Given this list of marker genes CDK5 (NCBI Gene Id 1020), NDUFA4, NDUFB7, MT-ND1, NDUFA3, NDUFB5, NDUFV1, NDUFB2, NDUFA7 (NADH:ubiquinone oxidoreductase subunit A7), NDUFB3, NDUFAB1 (NCBI Gene Id 4706), NDUFA6, NDUFS1, MT-ND4, NDUFS5, NDUFB11, NDUFS8, MT-ND2, CDK5R1, MT-ND6, CAPN1, NDUFS4, NDUFB9, NDUFS3, NDUFS2, NDUFC1 (NCBI Gene Id 4717), NDUFC2, MAPT, NDUFA11, NDUFB8, NDUFB10, NDUFA9, NDUFB1, NDUFA13, NDUFB4, NDUFS7, NDUFV2, MT-ND3, APP, CAPN2, NDUFV3, NDUFA12, NDUFA1, NDUFA2, NDUFS6, NDUFA5, MT-ND5 (NCBI Gene Id 4540), NDUFA10, CHRNA7, NDUFA8, NDUFB6, here is a description of the gene set: species: Homo sapiens Pathway Definition from KEGG: APP* -> Abeta -> CHRNA7 -> Ca2+ -> CAPN -> CDK5R1 == CDK5 -> MAPT -| CxI -> Q Mutation-caused aberrant Abeta to electron transfer in Complex I. Pathway ID: N00997. Pathway type: Variant. Pathway class: nt06460 Alzheimer disease. Human Gene Set: KEGG_MEDICUS_VARIANT_MUTATION_CAUSED_ABERRANT_ABETA_TO_ELECTRON_TRANSFER_IN_COMPLEX_I